The following is a description of a gene set: Human Gene Set: GOBP_POSITIVE_REGULATION_OF_STEROL_TRANSPORT Any process that activates or increases the frequency, rate or extent of the directed movement of sterols into, out of or within a cell, or between cells, by means of some agent such as a transporter or pore. studied in species Homo sapiens, and this is the list of marker genes: ABCA3, ABCA8, ABCA12, NFKB1, SCP2, COMMD1, ABCA7, PLTP, ABCA5, ABCG4, LIPG, MIR206, CETP, PTCH1 (patched 1), LDLRAP1, TREM2, CES1, ABCA13, ABCG1, NR1H2, ABCB4, EEPD1, ZDHHC8, LRP1, APOE, APOA1, RXRA, ABCA1, ANXA2P2, NR1H3, PPARG, GPS2, PON1, ADIPOQ, SIRT1, CAV1, ANXA2